Given this list of marker genes Cxcl11, Cxcl13, Cxcl9, Pf4, Cxcl10, here is a description of the gene set: Mouse Gene Set: GOMF_CXCR3_CHEMOKINE_RECEPTOR_BINDING studied in species Mus musculus Binding to a CXCR3 chemokine receptor.